Given this list of marker genes TRAF1, RIPK1, TNFRSF12A, BIRC2, MAPK9, JUN, MAPK1, NFKB2, CASP8, MAPK3, MMP9, NFKBIB, NFKBIA, MAPK14, CASP3, NFKB1, IKBKB, RAC1, MAPK8, IL6, AKT1, MAP3K7, TNF, BIRC3, AKT2, RELA, HDAC1 (NCBI Gene Id 3065), TRAF5, CCL5, CHUK, TRAF3, RAF1, TNFSF12, CCL2, CTNNB1, RELB, GSK3B, FADD, TRAF2, CASP7, MAP3K14, TRIM63, here is a description of the gene set: TNF-related weak inducer of apoptosis (TWEAK) signaling species: Homo sapiens Human Gene Set: WP_TNFRELATED_WEAK_INDUCER_OF_APOPTOSIS_TWEAK_SIGNALING